The following is a description of a gene set: Mouse Gene Set: GOMF_GALACTOSYLTRANSFERASE_ACTIVITY species: Mus musculus Catalysis of the transfer of a galactosyl group to an acceptor molecule, typically another carbohydrate or a lipid., and this is the list of marker genes: Wdfy3, B4galt6, B3galt2, Colgalt2, Abo, B4galt3, 4930568D16Rik (RIKEN cDNA 4930568D16 gene), B3galnt1, B4galt4, C1galt1c1, Lalba, Plod3, B3galt6, B4galt7, Ggta1, B3gnt6, Cercam, B4galt1, B4galt5, Colgalt1, B3gntl1, Ugt8a, B3galt1, A4galt (alpha 1,4-galactosyltransferase), B4galt2, B3galt5, C1galt1, A3galt2, B3galt4 (NCBI Gene Id 54218)